Given this list of marker genes GPN1, PDE8A, ZBTB34 (zinc finger and BTB domain containing 34), CDC14B, C7orf57, UQCR11, TMOD3, GAB3, ZSCAN12, MEIS3, TRAPPC11 (NCBI Gene Id 60684), IFITM10, TBC1D10A, NAP1L5, F2R, SELPLG, ANXA6, DUS4L, IL18RAP, DTX1, SLAMF7, PTPN21, TSPAN4, HECTD2, CUX1, PYCR3, SRP68, CST7, HMBOX1 (NCBI Gene Id 79618), HID1, MEN1, GBE1, CRYBG1, KATNB1, PAK6, RUNX3, SMPDL3B, GRAMD2B, PDLIM1, TXNDC5, HSD11B1, USP30 (ubiquitin specific peptidase 30), CDK5RAP3, IL18R1, SERPINB1, IL1RL1, CC2D1A, TIAM2, PIP5K1C, CDC42EP4, PBLD, PPP1R35, LAIR1, PEX16, CXCR3 (C-X-C motif chemokine receptor 3), ASB5, SASS6, IER3, LARS2, YES1, UST, RAB12, CD47, DET1, TASL, NXN, MYO6, ZNF654, SFXN1, FCGR2B, APOBR, TMUB2, TARS3, GABARAPL2, ITGB3, ZNF605, XYLB, KCNJ8, FGF13, GTPBP6, PIGK, CHPT1, NMNAT2, POU6F1, UQCC5, ST3GAL6 (NCBI Gene Id 10402), KLRD1 (NCBI Gene Id 92677), SUSD2, PLEKHB1, TENT5A, RBCK1, TACC1, CD7, DRG2, MYADM, TYSND1, DMAC1, KRTAP13-2 (NCBI Gene Id 337959), ANXA1, MBNL3, ABHD14B (abhydrolase domain containing 14B), NKG7, TIMM10, PLAC8, PAICS, SLC25A2, TRMT10C (NCBI Gene Id 54931), SPRTN, WDR76, CCL5, KCNK1, C1orf21, DNAJC15, NUP188, SMIM8, PLEK, ST7, TBC1D1, KCNK5, DSTN, DNAJB4, IFRD1, KLRC1, CACNA2D2, MRPS34, DDX49, SHROOM3, RPS27L, AP4S1, CLCC1, SNRPD1 (NCBI Gene Id 6632), UNC5CL, DYRK2, RCN1, DPP9, UBE2V2, EEF1E1, HM13, RPL37, PRSS12, EFEMP1, DCAF12L1, CDC40, WDR46, SLC66A1, DYNC2LI1 (dynein cytoplasmic 2 light intermediate chain 1), PTPN2, KLF16, TIPARP, PLP2, NIF3L1, CKAP5, CTSW, CKS2, EML3, MED12, CFAP91, VIPR1, SYTL2 (synaptotagmin like 2), GPATCH1, ADAM19, IL2RB, COBLL1 (NCBI Gene Id 22837), PTCD1, CLN3, STRBP, ART3 (NCBI Gene Id 419), RRAGC, ARSK, GANC, CRYBG2, YJU2B, VTI1A, ALAD, CEP72, SPO11, RPA2, CERCAM, CAPRIN2, CHSY1, PMS1, PELO, APIP, RPP21, PRDM1, PRICKLE3, NCEH1 (neutral cholesterol ester hydrolase 1), RCC1L, HMGA2, IKZF3, LGALS1, SUB1, ARHGAP15, MYO1F, MYL4 (NCBI Gene Id 4635), PREX1, CCR9, ZC2HC1C (NCBI Gene Id 79696), KLRK1, AFG1L, here is a description of the gene set: from publication Doronin K, Flatt JW, Di Paolo NC, Khare R, Kalyuzhniy O, Acchione M, Sumida JP, Ohto U, Shimizu T, Akashi-Takamura S, Miyake K, MacDonald JW, Bammler TK, Beyer RP, Farin FM, Stewart PL, Shayakhmetov DM (PMID 23019612) Discrimination between self vs. non-self and adequate response to infection and tissue damage are fundamental functions of the immune system. The rapid and global spread of known and emerging viruses is a testament that the timely detection of viral pathogens that reproduce within host cells, presents a formidable challenge to the immune system. To gain access to a proper reproductive niche, many pathogens travel via the host vasculature and therefore become exposed to humoral factors of the innate immune system. Although a cascade of coagulation factors plays a fundamental role in host defense for “living fossils” such as horseshoe crabs (Xiphosurida spp), the role of the coagulation system in activation of innate responses to pathogens in higher organisms remains unclear. When human type C adenovirus (HAdv) enters the circulation, 240 copies of coagulation factor X (FX) bind to the virus particle with picomolar affinity. Here, using molecular dynamics flexible fitting (MDFF) and high resolution cryo-electron microscopy (cryo-EM), we defined the interface between the HAdv5 hexon protein and FX at pseudo-atomic level. Based on this structural data, we introduced a single amino acid substitution, T424A, in the hexon that completely abrogated FX interaction with the virus. In vivo genome-wide transcriptional profiling revealed that FX-binding-ablated virus failed to activate a distinct network of the early response genes, whose expression depends on transcription factor NFKB1. Deconvolution of the signaling network responsible for early gene activation showed that the FX-HAdv complex triggers MyD88/TRIF/TRAF6 signaling upon activation of toll-like receptor 4 (TLR4) that serves as a principal sensor of FX-virus complex in vivo. Our study implicates host factor “decoration” of the virus as a mechanism to trigger innate immune sensor that respond to a misplacement of coagulation FX from the blood into intracellular macrophage compartments upon virus entry into the cell. Our results further the mounting evidence of evolutionary conservation between the coagulation system and innate immunity. Genes down-regulated in Lung dendritic cell from untreated wildtype mice versus Lung dendritic cell from untreated IL-1R mice. species: Homo sapiens Human Gene Set: GSE36078_WT_VS_IL1R_KO_LUNG_DC_DN